The following is a description of a gene set: from publication Querec TD, Akondy RS, Lee EK, Cao W, Nakaya HI, Teuwen D, Pirani A, Gernert K, Deng J, Marzolf B, Kennedy K, Wu H, Bennouna S, Oluoch H, Miller J, Vencio RZ, Mulligan M, Aderem A, Ahmed R, Pulendran B (PMID 19029902) Genes up-regulated in comparison of unstimulated peripheral blood mononuclear cells (PBMC) versus PBMC 3 days after stimulation with YF17D vaccine. Human Gene Set: GSE13485_CTRL_VS_DAY3_YF17D_VACCINE_PBMC_UP species: Homo sapiens The immune responses generated by YF-17D by profiling genes in 25 vaccine recipients were accessed at days 1, 3, 7, and 21 post-vaccination compared to pre-vaccination in PBMCs. The immune responses generated by YF-17D by profiling genes in 25 vaccine recipients were accessed at days 1, 3, 7, and 21 post-vaccination compared to pre-vaccination in PBMCs., and this is the list of marker genes: RGS16, TMEM231, SCN4B, SOX2-OT, STEAP4, WNT5A, WFDC10B, C11orf52, ADGRG3, PNRC1, FCRL4, IL1RAP, FOS, EOLA1, RBBP5, LYPD3, CACNG1, PTGER3, MARCHF11, CXCR2, TRIM67, TBC1D14, LINC00474, KCNH5, FFAR2, CAV3, SLC6A12, VAT1, EPAS1, OR2J3, CWF19L1, IMPG2, ANKHD1, CNTNAP3, HSPA2, ZFYVE9, TMEM254-AS1, BTF3, RORC, MUC15, NRN1, APH1A, ZFP30, GATA1, EOLA2, MXI1, ATP1B4 (ATPase Na+/K+ transporting family member beta 4), MAPK11, LINC00470, CFAP45 (NCBI Gene Id 25790), HFM1, CFAP52, NFYC-AS1, CA4, PI3, PKD1L1-AS1, ZNF430, ANTXR2, GNAT1, WNT9A, RARRES1 (retinoic acid receptor responder 1), MSRB1, RP1, LINC00923, ARIH2, SYS1, RARG (NCBI Gene Id 5916), LSM14B, CRKL, ANKRD30BP3, TNFRSF1A, CXCL1, LINC00347, PIK3CA, CFAP96, P2RY10, MPPED2, LHFPL3, DBH, PDRG1, JADE1, EXOSC3, KDM7A-DT, PCDHB13, ZNF749, LIMD1-AS1, GCC1, CYP4Z1, UGT2B28, THSD7A, TNFAIP6, CTBP1-AS, CEMIP, INHBB, DBIL5P, TFF3, LAMB2P1, MIR1915HG, CRYBA1, RPL23AP53, IFNG, H2AC15, OR10H1, CCR3, ZNF423, RARB, MTNR1B, PRDM5, SRSF8, MAK, DDR2, CFAP73, PCGF3-AS1, SLC13A2, KCNC3, CDH26, OR2L13, LINC00588, FEM1A, ANGPT1 (angiopoietin 1), DANCR, P2RY1, CNN3-DT, CCL20, PRIM2, CHI3L1, NOBOX (NOBOX oogenesis homeobox), LINC03086, AGO2, PRKAA2, ACOX1, ERLEC1P1, ANKRD7, WNT11, FRMD6, SDS, RAF1, ALOX5AP, NBL1, EPHB3, MYO10, ZNF491, DUSP10, EDA, PMEL, C8G, ITGB8, C20orf141, GJB6, NACC1, FBXL13 (NCBI Gene Id 222235), AQP9, MKNK1-AS1, FRAT1, BMS1, NRIP1, JUN, POLB, THBS2, SAFB, HAS1, CIMAP1A, RPL3, FBN3, TPTE2P6, RBM47, ADCY4, TAX1BP1, LITAF, ADGRF1, TRIM39, WEE2-AS1, ATOSA, TH, ZDHHC18, CA11, GCSAML, SLC30A4, FPR2, MPZL3, ARCN1, CCDC9, TGFBRAP1, SYTL3, MS4A8, LINC00528, ZNF586, SLITRK5, MTMR10, THUMPD3